The following is a description of a gene set: Human Gene Set: GOBP_POSITIVE_REGULATION_OF_TRANSCRIPTION_OF_NOTCH_RECEPTOR_TARGET The activation of transcription of specific genes as a result of Notch signaling, mediated by the Notch intracellular domain. studied in species Homo sapiens, and this is the list of marker genes: RBPJ, MAML3, MAML2, RBM15, NOTCH4, NOTCH1, MAML1